The following is a description of a gene set: part of: FLT3 signaling in disease Reactome Pathway: Signaling by FLT3 ITD and TKD mutants FLT3 is subject to internal tandem duplications (ITDs) of lengths varying from 3 to 1236 base pairs. These ITDs are generally found in the juxtamembrane domain, or more rarely, the first tyrosine kinase domain (TKD) and disrupt the autoinhibitory loop of the receptor, constitutively activating it. FLT3 ITDs are found in ~25% of acute myeloid leukemias (AMLs) and represent the most frequent mutation of this cancer<br>At lower frequency, FLT3 is subject to activating point mutations (~7% of AML cases). These mutations tend to cluster in the TKD, with mutation of the activation loop residue D835 and the gatekeeper F691 residue the most common sites. <br>FLT3 ITD and TKD mutants support cellular transformation through activation of downstream signaling pathways such as the MAP kinase, PI3K/AKT and STAT5 cascades. There is some debate about the extent to which the pathways activated by the ITD and TKD mutants are distinct, with some evidence that STAT5 signaling, in particular, is more characteristic of FLT3 ITD activation. studied in species Homo sapiens, and this is the list of marker genes: FLT3, PIK3R1, STAT5B, BCL2L1, PIK3CA, KRAS, GRB2 (NCBI Gene Id 80715), PTPN11, NRAS, CDKN1A, STAT5A, SOS1, GAB2, HRAS (NCBI Gene Id 338029), PIM1, NOX4